Given this list of marker genes Dcx, Cdk5, Pafah1b1, Reln, Adgrg1, Cdk5r1, Dab2ip, Ulk4, Mboat7, Gli3, Socs7, Cdk5r2, Lrp8, Bmerb1, Nr2e1, Ctnnb1, Col3a1, here is a description of the gene set: The detachment of cells from radial glial fibers at the appropriate time when they cease to migrate and form distinct layer in the cerebral cortex. species: Mus musculus Mouse Gene Set: GOBP_LAYER_FORMATION_IN_CEREBRAL_CORTEX